The following is a description of a gene set: Abnormal left ventricular end-diastolic volume Human Gene Set: HP_ABNORMAL_LEFT_VENTRICULAR_END_DIASTOLIC_VOLUME studied in species Homo sapiens Any deviation from the normal range of end-diastolic volume of the left ventricle, which is the volume of blood in the left ventricle at the end of diastole (just before systole)., and this is the list of marker genes: DSG2, TNNT2, VCL, DMD, TNNI3, CSRP3, ACTC1, TPM1 (tropomyosin 1), ADAMTS19, MYPN, PSEN2, NEXN, TAFAZZIN, MYBPC3, CRYAB, BAG3, FKTN, PSEN1, RAF1, BAG5, SGCD, MYH6, LDB3